The following is a description of a gene set: Human Gene Set: GOBP_POSITIVE_REGULATION_OF_CD4_POSITIVE_ALPHA_BETA_T_CELL_DIFFERENTIATION Any process that activates or increases the frequency, rate or extent of CD4-positive, alpha-beta T cell differentiation. studied in species Homo sapiens, and this is the list of marker genes: NCKAP1L, HLX (H2.0 like homeobox), IL2RG, BRD2, RARA, KLHL25, IL12RB1, CCL19, IL12B, BRD4, MALT1, CD86, SOCS5, NFKBIZ, SHB, NLRP3, SOCS1 (NCBI Gene Id 8651), IL23A, SASH3, IFNG, TNFSF4, ANXA1, PRKCZ, HLA-DRB1, EP300, HLA-DRA, FOXP3, CD83, NFKBID (NCBI Gene Id 84807), LGALS9, GPR65, RIPK2, CD80, MIR21, IL23R, IL4R, ZBTB7B, IL18, OPA1 (OPA1 mitochondrial dynamin like GTPase)